The following is a description of a gene set: studied in species Homo sapiens from publication Johnson K, Hashimshony T, Sawai CM, Pongubala JM, Skok JA, Aifantis I, Singh H (PMID 18280186) Genes up-regulated in IRF4 and IRF8 null pre-B cells treated with IL7: 5 ng/ml versus 0.25ng/ml. Human Gene Set: GSE10273_HIGH_VS_LOW_IL7_TREATED_IRF4_8_NULL_PRE_BCELL_UP Productive rearrangement of the immunoglobulin heavy chain locus triggers a major developmental checkpoint that promotes limited clonal expansion of pre-B cells, culminating in cell cycle arrest and rearrangement of the kappa (κ) or lambda (λ) light-chain loci. B lineage cells lacking the related transcription factors IRF-4 and IRF-8 undergo a developmental arrest at the cycling pre-B cell stage and are blocked for light-chain recombination. Using Irf-4,8-/- pre-B cells we demonstrate that two pathways converge to synergistically drive light-chain rearrangement, a process that is not simply activated by cell cycle exit. One pathway is directly dependent on IRF-4, whose expression is elevated by pre-BCR signaling. IRF-4 targets the κ 3′ and λ enhancers to increase locus accessibility and positions a kappa allele away from pericentromeric heterochromatin. The other pathway is triggered by attenuation of IL-7 signaling and results in activation of the κ intronic enhancer via binding of the transcription factor, E2A. Intriguingly, IRF-4 regulates the expression of CXCR4 and promotes the migration of pre-B cells in response to the chemokine CXCL12. We propose that IRF-4 coordinates the two pathways regulating light-chain recombination by positioning pre-B cells away from IL-7 expressing stromal cells. We used microarrys to identify the changes in gene expression under different levels of the cytokine IL-7 and after rescue of genetic defect., and this is the list of marker genes: TMEM205, PLCXD2, LDHB (NCBI Gene Id 3945), ADCY9, CD244, PARP8, DEPDC7, C1QTNF12, CNNM2, ZNF367, CCNYL1, PXN, HIPK3, IFTAP, CASP8AP2, APPL2, LACTB, TECPR2, CD34, BLTP3B, CDH1, KIF17, ZNF841, OXR1, HOMER2, ARHGAP39, HS1BP3, UBIAD1, PGLYRP1, POLR3A, CCDC88A, ANXA9, GNPDA1, FAM91A1, UBA5, INF2, GTF2IRD2, ZGRF1, MARCHF7, IGFBP4, GSDME, C6orf62, SLC25A36, RAB11FIP5, AGPAT5, CASD1, CELA1, EVI2A, CSF3R, RP2, ZNF710, TIRAP, CMTM3, SDAD1, TBC1D15, NSUN3, PDIA5, RAB34, CTSE, DOLK, NECAP1, TJP1 (NCBI Gene Id 7082), FNIP1, ZNRF3, ABCB10, UGDH, ADSS1, CCDC137, TAF1D, CPQ, ACAP2, CKAP4, KEL, S100A1, UBXN2A, ZNF347 (NCBI Gene Id 84671), HEXB, GPR160, NAGA, SLCO1C1, CLDN12, KICS2 (KICSTOR subunit 2), SECISBP2L, C1GALT1C1, SRP68, RHOB, LEPROT, FAM114A1, GFI1 (growth factor independent 1 transcriptional repressor), ELOVL5, UCHL5, STYX, ZNF704, FOSL2, GOLIM4, ACOX1, TWF1, RIN3, LONRF1, SLC40A1, CMTM6, FUCA2, EIF1AY, HSD17B1, NFKBIA, PAM, FAM199X, ENPP4, PLCB4, IKBKE, GANC, DAAM1, DGKG, CYP4V2, FAM13B, MAST3, CCDC93, FLNA, ELP1, ABCA9, GALNT6, CLTC, PPIP5K2, NCAPD3, PHLDB2, F10, OSBPL8, MBNL3, NFAM1, LHFPL2, ANKRD63, CYSLTR1, UVSSA, LTBR, FAM117B, PHIP, SH3BGRL, DHDH, DNMBP, GSTM3, CPD, FUT4, PSTPIP1, TRMT13, ACTR6, CPNE3, ZNF571, ZBTB44, CAMK2G, PSME4, IL15 (interleukin 15), COPA, ADCY7, TMEM170B, DIO2, ANKH, KDM5B, TMED2, ANGPTL4, C10orf88, RECK, RNF144B, MTMR6, DOCK1, FNDC3A, TGFBI, MFSD14A, SPACA9, SECISBP2, CTSV, GADD45B, GOLGA4, TRIM44, LDAF1, BCO1, PAQR3, ATAD5, MICALL1, ERLIN2, CDC6, IKZF2, VAPA, BFAR, QKI, DENND4C, NNT, FANCG, DCTN6, ZFC3H1, INTS6L (integrator complex subunit 6 like), PGAM1, IFITM3, SAT1, MOSPD2 (NCBI Gene Id 158747), WAPL (NCBI Gene Id 23063), POGLUT2, KDM7A, CFP, SNAP23, IL6R